Given this list of marker genes S100a10, Casp7, Sytl4, Anxa2, Rab3a, Myh9, here is a description of the gene set: species: Mus musculus Mouse Gene Set: GOBP_REGULATION_OF_PLASMA_MEMBRANE_REPAIR Any process that modulates the frequency, rate or extent of plasma membrane repair.